The following is a description of a gene set: Reactome Pathway: NR1H2 and NR1H3-mediated signaling The liver X receptors LXRα (NR1H3) and LXRβ (NR1H2) are members of the nuclear receptor superfamily and function as ligand-activated transcription factors. The natural ligands of NR1H2 and NR1H3 are oxysterols (e.g., 24(S),25-epoxycholesterol, 24(S)-hydroxycholesterol (OH), 25-OH, and 27-OH) that are produced endogenously by enzymatic reactions, by reactive oxygen species (ROS)-dependent oxidation of cholesterol and by the alimentary processes (reviewed in:Jakobsson T et al. 2012; Huang C 2014; Komati R et al. 2017). It has been shown that these oxysterols bind directly to the ligand-binding domain of LXRs with Kd values ranging from 0.1 to 0.4 microM. 24(S), 25-epoxycholesterol was found to be the most potent endogenous agonist (Janowski BA et al. 1999). NR1H3 (LXRα) and NR1H2 (LXRβ) showed similar affinities for these compounds (Janowski BA et al. 1999). In physiological conditions, oxysterols are formed in amounts proportional to cholesterol content in the cell and therefore the LXRs operate as cholesterol sensors to alter gene expression and protect the cells from cholesterol overload via: (1) inhibiting intestinal cholesterol absorption; (2) stimulating cholesterol efflux from cells to high-density lipoproteins through the ATP-binding cassette transporters ABCA1 and ABCG1: (3) activating the conversion of cholesterol to bile acids in the liver; and (4) activating biliary cholesterol and bile acid excretion (reviewed in: Wójcicka G et al. 2007; Baranowski M 2008; Laurencikiene J & Rydén M 2012; Edwards PA et al. 2002; Zelcer N & Tontonoz P 2006; Zhao C & Dahlman-Wright K 2010). In addition, LXR agonists enhance de novo fatty acid synthesis by stimulating the expression of a lipogenic transcription factor, sterol regulatory element-binding protein-1c (SREBP-1c), leading to the elevation of plasma triglycerides and hepatic steatosis (Wójcicka G et al. 2007; Baranowski M 2008; Laurencikiene J & Rydén M 2012). In addition to their function in lipid metabolism, NR1H2,3 have also been found to modulate immune and inflammatory responses in macrophages (Zelcer N & Tontonoz P 2006). The NR1H2 and NR1H3 molecules can be viewed as having four functional domains: (1) an amino-terminal ligand-independent activation function domain (AF-1), which may stimulate transcription in the absence of ligand; (2) a DNA-binding domain (DBD) containing two zinc fingers; (3) a hydrophobic ligand-binding domain (LBD) required for ligand binding and receptor dimerization; and, (4) a carboxy-terminal ligand-dependent transactivation sequence (also referred to as the activation function-2 (AF-2) domain) that stimulates transcription in response to ligand binding (Robinson-Rechavi M et al. 2003; Jakobsson T et al. 2012; Färnegardh M et al. 2003; Lin CY & Gustafsson JA 2015). Although both NR1H3 and NR1H2 are activated by the same ligands and are structurally similar, their tissue expression profiles are very different. NR1H3 is selectively expressed in specific tissues and cell types, such as the liver, intestine, adrenal gland, adipose tissue and macrophages, whereas NR1H2 is ubiquitously expressed (Nishimura M et al. 2004; Bookout AL et al. 2006). Upon activation NR1H2 or NR1H3 heterodimerizes with retinoid X receptors (RXR) and binds to LXR-response elements (LXREs) consisting of a direct repeat of the core sequence 5'-AGGTCA-3' separated by 4 nucleotides (DR4) in the DNA of target genes (Wiebel FF & Gustafsson JA 1997). An inverted repeat of the same consensus sequence with no spacer region(IR-0) and an inverted repeat of the same consensus sequence separated by a 1 bp spacer (IR-1) have also been shown to mediate LXR transactivation (Mak PA et al. 2002, Landrier JF et al. 2003). NR1H3 and NR1H2 have been shown to regulate gene expression via LXREs in the promoter regions of their target genes such as UDP glucuronosyltransferase 1 family, polypeptide A3 (UGT1A3) (Verreault M et al. 2006), fatty acid synthase (FAS) (Joseph SB et al. 2002a), carbohydrate response element binding protein (ChREBP, also known as MLX-interacting protein-like or MLXIPL) (Cha JY & Repa JJ 2007) and phospholipid transfer protein (PLTP) (Mak PA et al. 2002). LXREs have also been reported to be present in introns of target genes such as the ATP-binding cassette transporter G1 (ABCG1) (Sabol SL et al. 2005). NR1H3 has been shown to activate gene expression via the FXR-responsive element found in the proximal promoter of the human ileal bile acid-binding protein (FABP6) (Landrier JF et al. 2003). The NR1H2,3:RXR heterodimers are permissive, in that they can be activated by ligands for either NR1H2,3 (LXR) or RXR (Willy PJ et al. 1995). part of: Signaling by Nuclear Receptors studied in species Homo sapiens, and this is the list of marker genes: MIR144, CETP, PLTP, ABCG1, ABCG8, EP300, MIR26A2, NR1H2, NCOR2, ARL4C, APOC2, NRIP1, MIR26A1, GPS2, MOV10, RXRB, NCOA1, NCOR1, PCK1 (NCBI Gene Id 5105), TBL1XR1, AGO2, RXRA, MIR33A, MIR26B (NCBI Gene Id 407017), MIR33B, MYLIP, TBL1X, APOD, HDAC3, FASN, TNRC6C, KDM4A, ABCG5, KDM1A, APOC4, PLIN1, EEPD1, ANGPTL3, AGO3, SCD, KDM3A, TNRC6B, ABCA1, AGO4, SREBF1, FABP6, NR1H3, MIR613, AGO1, KDM1B, UGT1A3, APOE, TNRC6A, APOC1